Given this list of marker genes HRNR, KRT85, BMP4, MACROH2A2, PDZD7, SPRR2F, PALLD, SHARPIN, ANXA1, SLC4A7, CD109, FGF20, WNT5A, SGPP1, LCE3D, SPRR3, LCE4A, KRT80, STK4, SPRR4, ESRP1 (NCBI Gene Id 54845), PPL, SPRR1B, CDKN1A, EVPL, MAFB, MYO6, OPN3, PAX6 (NCBI Gene Id 5080), LCE1F, REG3G, SRSF6, SULT2B1, LCE2C, PKP1, POU3F1, ZFP36, KLK5, KRTAP6-1, IFT74, PPHLN1, AKR1C3, KRT81, NOTCH1, KRT76, EREG, YAP1, SFRP4, SPINK5, LIPK, ANKRD24, CLRN1 (NCBI Gene Id 7401), KRT82, PLS1, WDPCP, STRC, NME2, LCE1A, POU4F3 (POU class 4 homeobox 3), LCE1E, ZFP36L1, TXNIP, KRT3, CDH23, MYCL, LCE2D, SPRR1A, LIPN, CDH3, KRT6B, ERRFI1, HOXA7, AQP3, KEAP1, TCHH, NFKBIZ, SOD1, RBPJ, SPRR5, PAFAH1B1 (NCBI Gene Id 5048), IVL (NCBI Gene Id 3713), ROCK1, KRTAP6-2, CERS3, IL17A, KCNQ1, LCE3C, ATOH1 (atonal bHLH transcription factor 1), SPRR2B, MAFF, INTU, DLX3 (NCBI Gene Id 1747), GLI1, SPRR2G, OVOL3, POU2F3, HES5, KDF1, PTCH2, GLI2 (GLI family zinc finger 2), KRT1, VDR, MAP2K1, LATS1, TECTA, HES1 (hes family bHLH transcription factor 1), GSDME, GRHL1, IL20, HDAC2, SLITRK6, MYO7A, CASP3, LCE7A, PLEC, CTNNB1, FGF2, GATA6, LHFPL5 (LHFPL tetraspan subfamily member 5), TRIM16, ERCC3, JAG2, ADAM9, SFN, BCL11B, CDSN, LCE3B, EXTL3, CLIC4, GDF3, KRT74, LCE6A, SPRR2D, LORICRIN, S100A7, PIP5K1A, SAV1, ABCA12, IRF6, LCE1C, TMEM79 (NCBI Gene Id 84283), FOXN1, GRXCR2, MSX2 (NCBI Gene Id 8053), CNFN, SEC24B, KRT17, KRT79, DNASE1L2, ZBED2, KRT73, JAG1, FOXC1, KLF7, EZH2, BCR, ELMOD3, KRT83, KRT84, NCOA3, LCE2B, DSP, RAC1, CLRN2, FAM3C, KRT78, USH2A, MACROH2A1, SPRR2E, FLG, EPHA2, LCE3E, TP63, KAZN, TMEM132E, TMC1 (transmembrane channel like 1), PTCH1, SLC39A2, PRKCH, SCRIB, KRT75, UGCG, TGM3, LCE1B, FOXI3, EXPH5, LCE2A, ETV4, LIPM, KLF4, CSTA, CYP27B1, KRT5, KRT16, FLNB, TGM1, OVOL2 (ovo like zinc finger 2), GRXCR1, KRT86, FA2H, MIR125B1, KRT7, MAFG, ROCK2, TPRN, ALOX15B, KRTAP6-3, NHERF1, CASP14, CDKN2A, OVOL1, HEY2, LCE5A, LCE3A, ASAH1, KRT4, DLL1, ST14, REG3A, LATS2, WNT16, KRT14, SLC44A4, KRT6C, MINAR2, KRT71, CYP26B1 (NCBI Gene Id 56603), KRT36, FGFR1, TSG101, NUMA1, PPP3CA, MCOLN3, PLAAT4, TFAP2C, ERCC2, ACER1, FOSL2, REST, SCEL, KRT2, USH1C, LCE1D, TRIOBP, GRHL2, KRT72, DSG4, WHRN, KRT10, MYCN, KRT77, HDAC1, KRT6A, PITX2, MED1 (NCBI Gene Id 9327), here is a description of the gene set: studied in species Homo sapiens The process in which a relatively unspecialized cell acquires specialized features of an epidermal cell, any of the cells making up the epidermis. Human Gene Set: GOBP_EPIDERMAL_CELL_DIFFERENTIATION